The following is a description of a gene set: Human Gene Set: GOBP_RRNA_5_END_PROCESSING studied in species Homo sapiens Any process involved in forming the mature 5' end of an rRNA molecule., and this is the list of marker genes: UTP20, TBL3, NOP9, NOP14, ABT1